The following is a description of a gene set: Neighborhood of TTN titin in the MORF expression compendium Neighborhood of TTN Human Gene Set: MORF_TTN studied in species Homo sapiens, and this is the list of marker genes: CADM4, COL14A1, POLR1HASP, GCA, TTN, MLLT10, SERPINA4, NR1I2, RPS6KA5, CXCL5, KRT2 (keratin 2), TSSK2, NTNG2, SPA17, DBT, CDC73, HSD3B2, IGKV7-3, ABCB1, ABCB10, PTPRB, FSHR, GJB5, GLRA3, ADAMTSL3, IFNA1, ZNF141, IFNA10, JRKL, ZSCAN26, ZNF266, RREB1, CLCN3, MAP2, RORB, TMEM26 (NCBI Gene Id 219623), RAD51D, ZBTB40, GUCY2F (NCBI Gene Id 2986), PGM3, SUPT3H, JADE3, R3HCC1L, MAGEA8, KRT34, COL8A1 (NCBI Gene Id 57086), IFNA8, FBXL4, GPR171, PHOX2B